Given this list of marker genes FABP4, EBF2, MED26, SMAD4, RXRA, CDK19, MED13L, MTA2, PCK1, MED29, MED7, ADIRF, TGFB1, KLF4, MED24, GATAD2B, HNRNPU, BLNC1, BMP7, ZNF638, TBL1XR1, ANGPTL4, CHD9, THRAP3, NR2F2, CIDEA, HDAC1, CDK8, MED15, TBL1X, CCND3, KLF5, MED14, MED28, SREBF1, MED18, MED8, MED6, WNT10B (NCBI Gene Id 82499), CD36, LPL, MED1, MED21, MED9, MED11, SMARCD3, RBBP7, ELOVL3, PPARGC1B (PPARG coactivator 1 beta), CEBPA, NCOA1, ZNF423, MTA3, UCP1, MED4, MED20, MED25, CCNC, COX7A1, GATAD2A, PLIN1, MED22, MED19, NCOA6, PRDM16, MED16, TGS1, LEP, CHD4, CEBPD, MED23, HDAC2, CHD3, SLC2A4, PPARG, RELA, RBBP4, ADIPOQ, MED30, CARM1, NCOA3, HDAC3, PPARGC1A, PPARA, TNF, WNT1, EBF1, NCOR2, MED17, MED12, CDK4, MBD3, EGR2, ZNF467, SMAD1, EP300, NCOR1, MED13, MTA1, DIO2, MED27, CREBBP, FAM120B, MED10, NFKB1, NCOA2, MED31, HELZ2, SREBF2, CEBPB, here is a description of the gene set: studied in species Homo sapiens Adipogenesis is the process of development and differentiation of fat cells (adipocytes), the main cellular component of adipose tissues. Adipose tissues play an important role in the regulation of systemic energy levels. Two main types of adipocytes in mammals are white fat cells and brown fat cells. The third type, beige fat cells, are brown adipocyte-like cells that can develop in white adipose tissue in response to environmental stimuli.<br><br>The main function of white adipocytes is the storage and release of energy in the form of fatty acids in response to systemic metabolic cues.<br><br>The main function of both brown and beige adipocytes is the production of heat.<br><br>For review, please refer to Wang and Seale 2016. part of: Developmental Biology Reactome Pathway: Adipogenesis